The following is a description of a gene set: In this study, we found genes that change expression in the cortex and the medulla of the kidney with age. Some of the genes whose transcripts increase in abundance with age are known to be specifically expressed in immune cells, suggesting that immune surveillance or inflammation increases with age. The age-regulated genes show a similar aging profile in the cortex and the medulla, suggesting a common underlying mechanism for aging. Expression profiles of these age-regulated genes mark not only age, but also the relative health and physiology of the kidney in older individuals. Finally, the set of aging-regulated kidney genes suggests specific mechanisms and pathways that may play a role in kidney degeneration with age. Genes whose expression decreases with age in normal kidney. from publication Rodwell GE, Sonu R, Zahn JM, Lund J, Wilhelmy J, Wang L, Xiao W, Mindrinos M, Crane E, Segal E, Myers BD, Brooks JD, Davis RW, Higgins J, Owen AB, Kim SK (PMID 15562319) studied in species Homo sapiens Human Gene Set: RODWELL_AGING_KIDNEY_DN, and this is the list of marker genes: CCDC93, SRR, SELENBP1, THSD7A, DCBLD2, PLPPR1, ADH5, AUTS2, LINC02344, MPPED2, ZNF253, NLK, RTN4, ATP5MC3, KLF9, AASS, ITPR1-DT, CLDN8, SLC16A7, CYCS (cytochrome c, somatic), RHOBTB3 (Rho related BTB domain containing 3), YOD1 (NCBI Gene Id 55432), GNAS, FMO5, MMUT, DLAT, PALM, ECI2, GABARAPL3, CEP70 (NCBI Gene Id 80321), ADCY1, AMPD3, ESRRG, MPC1, UCHL5, CPEB3, CCNB1IP1, ENOSF1, GPRASP1, LRPPRC, ISCA1, FBXO3, FAM153A, SKIC8, H1-7, FNDC5, TPD52, TSPAN7, CACNB2, CACNA2D3, SLC4A1, BMP7, CSNK2A1, NUDT4, HERPUD2-AS1, LARGE2, UICLM, BBOF1, PPFIA1, CTH, SCML1, FXR1, GNG7, SLC25A36, CYB5RL, PEBP1, PEG3, VSIG10, ABTB3, B4GALNT3, MORN4, EGF, HDAC6 (histone deacetylase 6), LPL, OXCT1, AMT, RBM14, LDHB, BCKDHB, MTO1, TMEM38B, KLHL3 (NCBI Gene Id 26249), KLHL24, NEDD4L, TMPRSS2, GOT2, GMNN, SHANK2, FAXDC2, ABCA5, TMEM80, FBXO21, NUDT7, GHR, NF1, C1orf226, SP2 (Sp2 transcription factor), IMPACT (NCBI Gene Id 55364), ERLIN2, ATXN7L3B, WDFY2, HADHB, WNK1 (WNK lysine deficient protein kinase 1), AP5Z1, ISOC1, TOX3, GABARAPL1, FAM83F, PTGER3, SLK, KNG1, FRMD3, COX7C, KANK1, ARFGEF3, NDUFS1, ATP5F1A, NNT, CRABP1, GAD1, NEBL (nebulette), COX7B, DBT, ZBTB43, MTR, ZNF711, SULT1C2, SIAH2, ABTB2, UAP1, PPM1K, FOLH1, ERCC6L2-AS1, AK2, AFDN-DT, NAA35, OAT, PRKAA2, CIZ1, CEP15, SLC22A23, APLP2, TRPM6, MYBL1, PHYH, SOHLH2, PCLO, LINC00667